Given this list of marker genes Dctn4, Dynlt3, BC048507, Dctn1, Dynlrb2, Dynlt2a1, Dync2i1, Dync2h1, Dync1li2, Dynll1 (dynein light chain LC8-type 1), Dync1i1, Dynll2, Tpr, Dynlrb1, Dync1li1, Dync2i2, Dynlt5, Dync1h1, Dync2li1, Nudcd3, Snx4, Dynlt4 (NCBI Gene Id 280055), Dync1i2, Dynlt2b, Dynlt1b, here is a description of the gene set: Mouse Gene Set: GOCC_CYTOPLASMIC_DYNEIN_COMPLEX studied in species Mus musculus Any dynein complex with a homodimeric dynein heavy chain core that catalyzes movement along a microtubule. Cytoplasmic dynein complexes participate in many cytoplasmic transport activities in eukaryotes, such as mRNA localization, intermediate filament transport, nuclear envelope breakdown, apoptosis, transport of centrosomal proteins, mitotic spindle assembly, virus transport, kinetochore functions, and movement of signaling and spindle checkpoint proteins. Some complexes participate in intraflagellar transport. Subunits associated with the dynein heavy chain mediate association between dynein heavy chain and cargoes, and may include light chains and light intermediate chains.